The following is a description of a gene set: Hypoglycemic coma Coma induced by low blood sugar. studied in species Homo sapiens Human Gene Set: HP_HYPOGLYCEMIC_COMA, and this is the list of marker genes: HNF1A, AKT2, NNT, ETFDH, UCP2, MC2R, ETFB, ETFA, GCK, ABCC8, MRAP, STAR, HMGCL, NFKB2 (NCBI Gene Id 4791), HMGCS2, HADH, KCNJ11, GLUD1, INSR, TXNRD2